The following is a description of a gene set: The process in which a relatively unspecialized cell acquires specialized features of a hair cell. studied in species Homo sapiens Human Gene Set: GOBP_HAIR_CELL_DIFFERENTIATION, and this is the list of marker genes: POU4F3, WDPCP, FGF2, RBPJ, TMEM132E, TECTA, HEY2, SPINK5, MYO7A (NCBI Gene Id 4647), SCRIB, PITX2 (NCBI Gene Id 5308), DLX3 (NCBI Gene Id 1747), SEC24B, CLRN2, ERCC2, MYCN, REST, ATOH1, ELMOD3, PAFAH1B1, TPRN, KCNQ1, USH1C, MINAR2, TRIOBP, PLS1, FGFR1, GRXCR2, HES1, CDH23, SOD1, NHERF1, SLC4A7, JAG1, ESRP1 (NCBI Gene Id 54845), STRC, ANKRD24, NOTCH1, GRXCR1, CLRN1, LHFPL5, USH2A, JAG2, BMP4, SLITRK6, SLC44A4, CTNNB1, TMC1, MYCL, WHRN, MCOLN3, HES5, GSDME, MYO6, PDZD7, FGF20, DLL1, RAC1, ERCC3